The following is a description of a gene set: Genes predicted to be targets of miRBase v22 microRNA hsa-miR-7848-3p in miRDB v6.0 with MirTarget v4 prediction scores > 80 (high confidence targets). species: Homo sapiens Human Gene Set: MIR7848_3P from publication Chen Y, Wang X (PMID 31504780), and this is the list of marker genes: TACO1, TMEM181, SERTAD2, PDZD2, MTHFD2L, ARID1B, PELO, PELI2, INHBC, BBX, SYNCRIP, ADRB2, KRT23, BLZF1, FUT10, ACOT13, NUCKS1, MDGA2, RYR2, EP300, CLCN4, RORA, PXYLP1, G6PC1, VAPA (NCBI Gene Id 9218), ZNF503, NRG4, TGFBR3